Given this list of marker genes EPRS1, VARS1, FARSA, NARS1, TARS1, QARS1, GARS1, LARS1, AIMP2, WARS1, MARS1, DARS1, RARS1, SARS1 (seryl-tRNA synthetase 1), CARS1, FARSB, EEF1E1, YARS1, IARS1, PPA1, AARS1, KARS1, AIMP1, HARS1, here is a description of the gene set: studied in species Homo sapiens Cytosolic tRNA synthetases catalyze the reactions of tRNAs encoded in the nuclear genome, their cognate amino acids, and ATP to form aminoacyl-tRNAs, AMP, and pyrophosphate. Eight of the tRNA synthetases, those specific for arginine, aspartate, glutamate and proline, glutamine, isoleucine, leucine, lysine, and methionine, associate to form a complex with three accessory proteins. Each of the component synthetases is active in vitro as a purified protein; complex formation is thought to channel aminoacylated tRNAs more efficiently to the site of protein synthesis in mRNA:ribosome complexes. part of: tRNA Aminoacylation Reactome Pathway: Cytosolic tRNA aminoacylation